Given this list of marker genes PDF, NADSYN1, TGM2, HINT3, NGLY1, FAAH, HDAC6 (NCBI Gene Id 100820762), ASAH2, NIT1, HDAC4, ASPA, HDAC1, FAAH2, ASAH2B, UPB1, NDST1, CAT, VNN2, HINT2, AGA, ASAH1 (N-acylsphingosine amidohydrolase 1), NAAA, ACER1, NDST2, PARK7, HDAC3, HDAC7, GLS2, HDAC10, PGLYRP1, PGLYRP2, AMDHD2, FHIT, SIRT5, ACR, PM20D2, VNN1, HDAC2, CAD, HINT1 (histidine triad nucleotide binding protein 1), SIRT4, SIRT2, ACY1, NDST4, PM20D1, PGLYRP4, BTD, DARS1, AFMID, ACY3, ASRGL1, NAALAD2, NTAQ1, HDAC5, NTAN1, HDAC8, PIGL, KLK3, HDAC11, NIT2, ACER2, ASPG, PGLYRP3, HDAC9, SIRT1, GLS, SIRT6, ACER3 (NCBI Gene Id 55331), here is a description of the gene set: Human Gene Set: GOMF_HYDROLASE_ACTIVITY_ACTING_ON_CARBON_NITROGEN_BUT_NOT_PEPTIDE_BONDS_IN_LINEAR_AMIDES Catalysis of the hydrolysis of any non-peptide carbon-nitrogen bond in a linear amide. studied in species Homo sapiens